The following is a description of a gene set: Human Gene Set: GSE19825_NAIVE_VS_IL2RALOW_DAY3_EFF_CD8_TCELL_DN from publication Kalia V, Sarkar S, Subramaniam S, Haining WN, Smith KA, Ahmed R (PMID 20096608) Genes down-regulated in comparison of naive CD8 T cells versus effector CD8 IL2RA low T cells at. CD25, the high affinity interleukin-2 (IL-2) receptor alpha-chain, is rapidly upregulated by antigen-specific CD8+ T cells after T cell receptor stimulation. We demonstrated that during an acute viral infection, CD25 expression was dynamic, and a subset of virus-specific CD8+ T cells sustained CD25 expression longer than the rest. Examination of the in vivo fate of effector CD8+ T cells exhibiting differential responsiveness to IL-2 revealed that CD25lo cells, which were relatively less sensitive to IL-2, preferentially upregulated CD127 and CD62L and gave rise to the functional long-lived memory pool. In contrast, CD25hi cells that accumulate enhanced IL-2 signals, proliferated more rapidly, were prone to apoptosis, exhibited a more pronounced effector phenotype, and appeared to be terminally differentiated. Sustained IL-2 receptor signaling resulted in increased CD8+ T cell proliferation, higher granzyme B expression and exaggerated contraction after antigen clearance. These data support the hypothesis that prolonged IL-2 signals during priming promote terminal effector differentiation of CD8+ T cells. species: Homo sapiens, and this is the list of marker genes: JRK, NFIC, PGP, TAF6, HAUS3, ASB2, ESS2, STYX, ING3, ENTPD1, PYROXD1, PTGER2, FAM20B, PROCR, TAX1BP3, MED29, COX20, SPG7, ATP5MG, TJP3, LAMP1, SMCO4, ILK, SAFB2, NAPEPLD, YEATS2, NMRK1, PIP4K2B, CHST12, RALA, GDPD5, UBE2V2, LAMB3, CIZ1, VTI1A, ERI3, CD84, CCDC85B, BCKDHA, GNAI2, PHIP, SRF, CWF19L1, MTOR, SMDT1, DROSHA (NCBI Gene Id 54746), LACC1 (NCBI Gene Id 144811), CC2D1A, RMDN1, HINT3, LRWD1, SIDT2, MINDY2, MYL11, BNIP1, TAF1C, GTF3C6, MAPK11, SLC4A1AP, C1orf53, ARL4A, PRKDC, CDC14B, SQLE, IFIH1, HMCES, GRK6, DDX18, TXLNA, CLN6, SYNJ1 (synaptojanin 1), MBOAT7, BTAF1, TRMT5, PRKAB2, ERCC1, SLF1, DENND1B, MTERF2, GLRX2, URB2, INIP, BRPF1, BET1L (NCBI Gene Id 93155), RAD51C, ZNF672, RNPEPL1, SLC39A8, EXOC6, PRDX1, MTA2, ZNF296, SLC39A14, EIPR1, PRPF8, REL, TPCN1, CDK16, PBX2, RCE1, AMMECR1, PMPCB, DUSP19, MCOLN1, OFD1, EIF5A2 (NCBI Gene Id 57114), TGFB1, CHADL, CYB5R1, CHMP6, SLC39A10, FOXRED2, ARPP19, LSM6, RALGAPB, MIR22HG, P4HTM (prolyl 4-hydroxylase, transmembrane), TRNAU1AP, SREK1, CLPTM1, DEXI, JMJD6, VAC14, TJP2, MANBAL, VPS36, ZBTB22, ORC2, PDCD2, MRPL36, GEN1, REXO1, TRAK1, SDC3, CLCC1, PAOX, PRKRA, SDCCAG8, NRDC, LPCAT1, MPEG1, MYO1G, SREBF1 (NCBI Gene Id 6720), NECAP2, BAX, SEC61G, NDUFA6, VWA8, WASHC3, RAB31, ANKRD17, RETREG2 (NCBI Gene Id 79137), FBXO5, LAMTOR4, PRNP, TRAPPC5, HIKESHI, ATXN1L, URM1 (ubiquitin related modifier 1), RNF126, NAA15, C8orf33, APLF, CHCHD1, POLR1B, GADD45G, RIF1 (replication timing regulatory factor 1), AP4B1, ETHE1, ERMP1, CIBAR1, LIMD1, PHF2, DIAPH2, CENPJ, C1orf122, LPP-AS2, GRAP, DBT, PHAF1, FBXO31, AUP1, XAF1, SULT2B1, GARS1, CD9, SCRIB, PRMT6, CASP4, FRRS1, VPS39, CCNJ, CCDC174, KDM4A, GADD45GIP1, FAS, NOP58, NDUFAB1, NSMF, SAYSD1 (SAYSVFN motif domain containing 1)